The following is a description of a gene set: Any process that generates a purine-containing compound, any nucleobase, nucleoside, nucleotide or nucleic acid that contains a purine base, from derivatives of them without de novo synthesis. Mouse Gene Set: GOBP_PURINE_CONTAINING_COMPOUND_SALVAGE species: Mus musculus, and this is the list of marker genes: Dck, Nmnat2, Adss1, Nadsyn1, Dguok, Ada, Nmnat1, Mtap, Naprt, Impdh2, Adk, Adsl, Ampd3, Gmpr, Gmps (NCBI Gene Id 229363), Nmnat3, Nmrk1, Adss2 (NCBI Gene Id 98302), Pgm2, Aprt, Gmpr2, Slc25a51 (solute carrier family 25, member 51), Pnp2, Impdh1, Ampd1, Pnp, Nampt, Nmrk2, Hprt1, Ampd2